Given this list of marker genes Nkx3-1, Foxh1, Naglu (NCBI Gene Id 27419), Prox1, Fuz, Kat6a, Hey1, Sox4, Dnm2, Bmpr1a, Chd7, Hectd1, Mir145a, Eng, Fkbp10, Lep, Ndst1, Adamts6, Sec24b, Hes1, Sufu, Dll4, Prickle1, Tab1, Robo2, Ltbp1, Pdgfrb, Dctn5, Tbx2, Robo1, Srf, Ephb4, Enpp1, Cxcr4, Fgf8, Kif7, Lrp2, Jag1 (NCBI Gene Id 170642), Eya1, Pcdha9, Notch1, Gla, Pde2a, Mir143, Hey2, Tgfb2, Aplnr, Lox, Chrd, Prdm1, Tgfbr2, Ngfr, Pkd2, Snx17, Efemp2, Mylk, Nprl3, Ednra, Notch4, Ap2b1, Acvrl1 (NCBI Gene Id 11482), Gaa, Myh10, Lrp1, Fam3d, Egr2, Megf8 (multiple EGF-like-domains 8), Smarca4, Col3a1, Adamts9, Tfap2b, Tbx1, Efnb2, Cntrl, Six1, Plxnd1, Smad6, Rbpj, here is a description of the gene set: The progression of the aorta over time, from its initial formation to the mature structure. An aorta is an artery that carries blood from the heart to other parts of the body. Mouse Gene Set: GOBP_AORTA_DEVELOPMENT species: Mus musculus